The following is a description of a gene set: studied in species Mus musculus The directed movement of a neutrophil cell, the most numerous polymorphonuclear leukocyte found in the blood, in response to an external stimulus, usually an infection or wounding. Mouse Gene Set: GOBP_NEUTROPHIL_CHEMOTAXIS, and this is the list of marker genes: Ccl21b, Ccl19-ps1, Ccl19-ps6, Pikfyve, Prkca, Dpep1, Dpp4, Lgals3, Ccl3, Cxcl5, Ccl19-ps4, Cxcl3, Dapk2, Cxcl1, Il17b, S100a9, Sell, Tgfb2, Srp54a, Itgb2l, Itga1, Bst1, Ccl21e, Slc37a4, Fcer1g, Mcu, Slit2, Cd74, C1qbp, C3ar1, Edn2, Cxcl10, Cx3cl1, Vav3, Ednra, Ccl19, Mdk, Gbf1, S100a8, Pde4b, Il1b, Cxadr, Ifng, C5ar2, Gm5849, Jam3, Xcl1 (chemokine (C motif) ligand 1), Bsg (NCBI Gene Id 12215), Tirap, Prex1, Jaml, Rac1, Edn3, Ccl21d, Ccl2, Pde4d, Il23a, Cxcl13, Ccl19-ps5, Cxcr2, Dysf, Ripor2, Ccr7 (NCBI Gene Id 12775), Fcgr3, Cxcl15, Cxcl2, Cxcl9, Camk1d, Ccl21a, Trem3, Ccl21f, Ppia, Dnm1l, Mospd2, C5ar1, Rac2, Pf4, Ccl19-ps3, Ccl28, Nckap1l, Nod2, Itgb2, Ccl27a, Edn1, Syk, Itgam, Tnfaip6, Cklf, Vav1, Lbp, Csf3r, Perp, Thbs4, Ppib, Ppbp, Cxcr1, Mpp1, Spp1, Trem1, Itga9